Given this list of marker genes SPAG5, DTYMK, ECT2, PLK4, MNS1, CLN6, BIRC5, ZNF252P, ASPM, CENPF, here is a description of the gene set: studied in species Homo sapiens from publication Semba S, Trapasso F, Fabbri M, McCorkell KA, Volinia S, Druck T, Iliopoulos D, Pekarsky Y, Ishii H, Garrison PN, Barnes LD, Croce CM, Huebner K (PMID 16407838) Human Gene Set: SEMBA_FHIT_TARGETS_DN Genes down-regulated in H1299 cells (non-small cell lung cancer, NSCLC) expressing the Y144F mutant form of FHIT. The Fhit tumor suppressor binds and hydrolyses diadenosine polyphosphates and the Fhit-substrate complex has been proposed as a proapoptotic effector, as determined by infection of susceptible cancer cells with adenoviruses carrying wild-type fragile histidine triad (FHIT) or catalytic site mutants. The highly conserved Fhit tyrosine 114 (Y114), within the unstructured loop C-terminal of the catalytic site, can be phosphorylated by Src family tyrosine kinases, although endogenous phospho-Fhit is rarely detected. To explore the importance of Y114 and identify Fhit-mediated signaling events, wild-type and Y114 mutant FHIT-expressing adenoviruses were introduced into two human lung cancer cell lines. Caspase-dependent apoptosis was effectively induced only by wild-type but not Y114 mutant Fhit proteins. By expression profiling of FHIT versus mutant FHIT-infected cells, we found that survivin, an Inhibitor of Apoptosis Protein (IAP) family member, was significantly decreased by wild-type Fhit. In addition, Fhit inhibited activity of Akt, a key effector in the phosphatidylinositol 3-OH kinase (PI3K) pathway; loss of endogenous Fhit expression caused increased Akt activity in vitro and in vivo, and overexpression of constitutively active Akt inhibited Fhit-induced apoptosis. The results indicate that the Fhit Y114 residue plays a critical role in Fhit-induced apoptosis, occurring through inactivation of the PI3K-Akt-survivin signal pathway.